Given this list of marker genes PDHX, PLK4, KAT5, ERCC2, GPSM2 (G protein signaling modulator 2), SUPT16H, LRP2, KIDINS220, RNF113A, TCF12, MAN2C1, AMER1, TUBB2B, DHCR7, TMEM260 (NCBI Gene Id 54916), TBCK, GTF2H5, PTCH1, TARS1, SRPK3, MED12, HECTD4, TUBB, ACBD6, CDC40, L1CAM, SLC25A19, RNU4ATAC, PDHA1, MDH1, LRRC32, DHCR24, OSTM1, TRAPPC12, ARID1B, AARS1, FRA10AC1, NSD1, ROBO1, KATNB1, TUBB3, LONP1, GLI2, FRMD4A, DDX3X, WDR4, C2CD3, CRPPA, LRPPRC, CDK5RAP2, KDM5B, ERCC3, TNR, MRPS25, MPLKIP, CLCN3, GTF2E2 (general transcription factor IIE subunit 2), PLCH1, CENPE, CARS1, TUBA1A, here is a description of the gene set: Partial agenesis of the corpus callosum Human Gene Set: HP_PARTIAL_AGENESIS_OF_THE_CORPUS_CALLOSUM studied in species Homo sapiens A partial failure of the development of the corpus callosum.